The following is a description of a gene set: Human Gene Set: MIR4295 species: Homo sapiens from publication Chen Y, Wang X (PMID 31504780) Genes predicted to be targets of miRBase v22 microRNA hsa-miR-4295 in miRDB v6.0 with MirTarget v4 prediction scores > 80 (high confidence targets)., and this is the list of marker genes: CCNY, THOP1, USP33, MBNL1, CHD5, FMR1, BTBD3, BTAF1, ZNF594, POU3F2, RNF216, CBLB, UBE3B, DLL1, KCNA4, MPHOSPH9, LDLR, ADCY1, AKAP1, FIBIN, LGALSL, TGFBR1, VCF1, CNOT6, DGKE, ARHGAP12, BMPR2, RACGAP1, DENND10, DSG1, SMARCD2, ABRAXAS2, LONRF3, ACBD3, CAMSAP2, SH3D19, IMPDH1, TES, DLG5, GAREM1, BTBD7, PPP1R15B, EPC2, RASD1 (NCBI Gene Id 63428), FZD6, SPEN, WDFY3, DNAJC16, UBB, DOCK3, CUL3, ROBO2, ZBTB20, MBD2, CD69, RFX7, ELK3, MAF, PHF12, MAP3K12, PAN3, RTN1, TRIM2, AR, FASTK, ERP44, SPATA2, APPL1, CD2AP, SNX2, BLCAP, SYT6, BAHD1, USP13, CLCN5, NSD3, ARHGAP1, TGFBR2, SLC44A1, PDIK1L, BTG1, PAK6, SBNO1, CEP170, PURG, PRUNE2, C2orf15, MFSD6, IRF1, HOXD1, G3BP2, FSTL5, FAT3, ATP12A, ARHGEF4, NHLH2, AGO4, FYN, SYBU, FERMT2, CCDC6, PSD (pleckstrin and Sec7 domain containing), CYP2U1, CALM2, KIAA1191, ABCB7, SCUBE3 (signal peptide, CUB domain and EGF like domain containing 3), RAI2, MAP3K20, TMEM250, PRKD3, ZBTB18 (zinc finger and BTB domain containing 18), UBE2W, PHACTR2, PTPRG, NALF1, ARL6IP1, EDN1, WDR33, IL1RAP, TET3, ATG14, CBX6, TNRC6C, NFIA, FMC1, DAAM1, SLMAP, GTF2H1, EBF3, POP7, ZNF609, CNOT4, ACVR1, LDLRAD4, CPEB3, ITPR1, EREG, CAPRIN2, KRTAP26-1, BTF3L4, RTCA, CDK19, LMLN, PGM2L1, WDR20 (WD repeat domain 20), LY75, TSC1, SKIDA1, FOXF2, FRMD6, MACIR, ABCC5 (ATP binding cassette subfamily C member 5), ATG16L1, TSPOAP1, MAPK1, KDM2A, MMGT1, OSBPL6, HIVEP2, ZNF3, PHF20, PTPN4, SZRD1, BAG5, SNX5, CLTC (NCBI Gene Id 9511), G0S2, VPS13D, FOSL1, MET (NCBI Gene Id 4233), TLCD3A (NCBI Gene Id 79850), MID1IP1, PHF14, ITPRIPL2, RBBP8, UBA3, STON2, KLF7, DNAL1, PPARG, DCAF8, GJA1, ST18, RRAGD, TRPC3, SNX31, PIK3CB, FRZB, SOCS5, SLAIN1, NPAT, SLC6A6, SRSF2, ARAP2, ZFYVE26, RNF145, CLCN3, PIP4P2, OTUD3, KIF13A, VGLL4, SBF2, CFL2, MSMO1, LSMEM1, R3HDM1, MDM4, INSIG1, LRP6, SPOCK1, GADD45A, ZNF862, BMP3, EMX2, RAD51B, AKIRIN2, VPS37A, UBE2D2, NEUROG1, DIAPH3, JADE1, KMT2C, AGO1, FUT9, NRBF2, NPEPL1 (NCBI Gene Id 79716), HCFC2, RAB5A, WEE1, ZNF217, FBXO48, POU4F1, STX6, MDFIC, EOGT, PIGA, ZEB2, CRACD, CPEB1, SEL1L3, MLLT6, ADAM12, SPHK2, WNK1, WDR47, NPNT, RBM25, ZNF107, LPGAT1, YTHDF2, DDX6, DCUN1D3, HECW2, ACSL4, EIF4E2, CHST1, RAB12, LRRTM2, SOS2, HEG1, TMOD1, LDAF1, ZFYVE9, NACC2, RUNX3, ZMAT3, LCORL, ENPP5, MB21D2, ADGRB3, ITGB8, RO60, USP28, ABHD3, SERBP1, PLAA, CCDC126, SAMTOR, SNIP1, CLIP1, SAMD8, DPYSL2, DYNLL2, RAPGEF4 (NCBI Gene Id 11069), PIKFYVE, UBXN2B, SPTY2D1, PPFIA2 (PTPRF interacting protein alpha 2), IL15, JMY, THSD7A, TBL1XR1, EGLN3, IGF1, AGFG1, MECP2, ATP6V1B2 (NCBI Gene Id 526), CENPO, TAFA1, PMEPA1, LRP2, CDS1, INO80, HOXA3, PSAP, TSHZ1, LRP12, PTP4A1, APCDD1, SAR1B, FSD1L, PLCB1, EPS15, LRIG1, TOGARAM1, PEX5L, FBXO28, CNOT7, JARID2 (jumonji and AT-rich interaction domain containing 2), ARHGAP21, AKAP11, TENT2, SLC2A4RG, ST8SIA5, SHANK2, TEX2, SECISBP2L, STIM2, CGGBP1, KBTBD8, SERINC3, TFCP2L1, PDZD11, SALL3, NFIB, ANKIB1, USP8, DLC1, SULF1, RAP2C, CYSLTR1, NECTIN3, PCNX1, DICER1, BPTF, CSMD1, HSPA8, SMOC1, ZNF800, MYBL1, PHAF1, MTCL1, HPRT1, MIGA2, ING2, ZBTB4, RPS6KA5, ERCC4, DSEL, ESR1, HS3ST5, CASD1 (CAS1 domain containing 1), DYNC1LI2, BRWD3, ERBIN, NCKAP5, MIER1, PPP6R2, DCBLD2, MBNL3, PIK3C2A, ASXL2, SFMBT1, AAK1, CBFB, TANC2, TMEM50B, CBY1, BRWD1, RALGPS2, RNF38, MIGA1, ARHGEF26, DENND4C, LRP8 (LDL receptor related protein 8), SPART, ACBD5, ULK2, PRKAA1, HECA, NABP1, MTMR10, RAB30, BHLHE41, ACSL1, MEMO1 (mediator of cell motility 1), LRP4, SIX4